The following is a description of a gene set: Reactome Pathway: Disorders of Developmental Biology Developmental disorders affect formation of body organs and organ systems. The causes of defects in human development are diverse and incompletely understood, and include environmental insults such as nutrient deficiency, exposure to toxins and infections Committee on Developmental Toxicology 2000, Taylor and Rogers 2005, Zilbauer et al. 2016, Izvolskaia et al. 2018), as well as genetic causes such as aneuploidy and other chromosomal abnormalities, and germline mutations in genes that regulate normal development. So far,we have annotated the role of loss-of-function mutations in methyl-CpG-binding protein 2 (MECP2), an epigenetic regulator of transcription, in Rett syndrome, a pervasive developmental disorder.<br><br>Disorders of myogenesis are rare hereditary muscle diseases that in the case of congenital myopathies are defined by architectural abnormalities in the muscle fibres and in the case of muscular dystrophies by increased muscle breakdown that progresses with age. Mutations in cadherin family genes are present in some types of muscular dystrophy.<br><br>Disorders of pancreas development result in pancreatic agenesis, where a critical mass of pancreatic tissue is congenitally absent. For example, the PDX1 gene is a master regulator of beta cell differentiation and homozygous deletions or inactivating mutations in PDX1 gene cause whole pancreas agenesis. PDX1 gene haploinsufficiency impairs glucose tolerance and leads to development of diabetes mellitus.<br><br>Left-right asymmetry disorders are caused by mutations in genes that regulate the characteristic asymmetry of internal organs in vertebrates. Normally, cardiac apex, stomach and spleen are positioned towards the left side, while the liver and gallbladder are on the right. Loss-of-function mutations in the CFC1 gene, whose protein product functions as a co-factor in Nodal signaling, result in heterotaxic phenotype in affected patients, manifested by randomized organ positioning.<br><br>Congenital lipodystrophies are characterized by a lack of adipose tissue, which predisposes affected patient to development of insulin resistance and related metabolic disorders. The severity of metabolic complications is correlates with the extent of adipose tissue loss. Loss-of-function mutations in the PPARG gene, encoding a key transcriptional regulator of adipocyte development and function, are a well-established cause of familial partial lipodystrophy type 3 (FPLD3).<br><br>Congenital stem cell disorders are caused by mutations in genes that regulate the balance between stem cells maintenance and commitment to differentiated lineages. Loss-of-function mutations in the SOX2 gene, which encodes a transcription factor involved in the maintenance of totipotency during embryonic preimplantation period, pluripotency of embryonic stem cells, and multipotency of neural stem cells, are the cause of anophthalmia (the absence of an eye) and microphthalmia (the presence of a small eye within the orbit.<br><br>HOX-related structural birth defects are caused by loss-of-function mutations in HOX family genes.HOX transcription factors play a fundamental role in body patterning during embryonic development, and HOX mutation are an underlying cause of many congenital limb malformations.<br><br>Congenital keratinization disorders are caused by dominant negative mutation in keratin genes and depending on where the affected keratin gene is expressed, they affect epithelial tissues such as skin, cornea, hair and/or nails.<br><br>Disorders of immune system development are caused by mutations in genes that regulate differentiation of blood cell lineages involved in immune defense, leading to immune system defects. For example, mutations in the gene encoding CSF3R, a receptor for the granulocyte-colony stimulating factor, result in congenital neutropenia, characterized by a maturation arrest of granulopoiesis at the level of promyelocytes. Patients with severe congenital neutropenia are prone to recurrent, often life-threatening infections from an early age and may be predisposed to myelodysplastic syndromes or acute myeloid leukemia. species: Homo sapiens part of: Disease, and this is the list of marker genes: MECP2, DPY30, BDNF, TBL1XR1, TBL1X, RBBP5, CAMK4, KMT2D, PRKACA (protein kinase cAMP-activated catalytic subunit alpha), CALM1, GPS2, WDR5, ASH2L (NCBI Gene Id 9070), SIN3A, HDAC1, NCOR2, HDAC3, NCOR1